Given this list of marker genes STAT3, MPV17L, FYN, HP, MT3, HDAC6, here is a description of the gene set: Human Gene Set: GOBP_NEGATIVE_REGULATION_OF_HYDROGEN_PEROXIDE_METABOLIC_PROCESS Any process that decreases the frequency, rate or extent of the chemical reactions and pathways involving hydrogen peroxide. studied in species Homo sapiens